Given this list of marker genes Ak3 (NCBI Gene Id 56248), Ak9, Itpkc, Itpkb, Pmvk, Gm17949, Nme6, Nme7, Ak2 (adenylate kinase 2), Ak7, Nme4, Cmpk1, Ppip5k1, Nme3, Nme5, Guk1, Ak1, Itpka (NCBI Gene Id 228550), Ip6k2, Lrguk, Cmpk2, Pck1, Ak8, Ip6k1, Uap1, Pals2, Nme1, Ak5, Nme2, Pals1, Ppip5k2, Ak6 (adenylate kinase 6), Ip6k3, Ak4, Dtymk, here is a description of the gene set: Mouse Gene Set: GOMF_PHOSPHOTRANSFERASE_ACTIVITY_PHOSPHATE_GROUP_AS_ACCEPTOR Catalysis of the transfer of a phosphorus-containing group from one compound (donor) to a phosphate group (acceptor). species: Mus musculus